Given this list of marker genes TMCO1, FOXN2, S100A11, MGST2, MTPN, PHYH, MICOS10, CHI3L1 (NCBI Gene Id 7836), MTM1, ECPAS (NCBI Gene Id 23392), CD68 (NCBI Gene Id 968), PDK3, FN1 (NCBI Gene Id 2335), RBBP9, IL15, STRAP, RAP1A, PDCD4, CASP1, TUBB6, OAT, ACTR2, NPAS1, C1orf43, LGALS4, PRDX2, SOCS2, CRIP1 (cysteine rich protein 1), FRRS1, ZNF808, TMEM167A, IFI30, TG, ITM2C, GLO1, SSPN, INPPL1, GNL2, UBE2E1, TUBB2A, ITM2B, TPD52, ARID3A, ADSS1, CHD1, RNF208, RAD54L, RNASE4, C15orf39, TAGLN2, TMEM131, RNASEH2B, MFHAS1, S100A6, RIDA, PPP2CB, GPHN, SCAMP1, SEPTIN2, S100A10, NID1, NEK2, SLC25A15, GGH, GIMAP4, NUDT19, FGL2, VMP1, LIPC, ASS1, INPP5A (NCBI Gene Id 3632), CDK5RAP3, SH3BGRL2, SBF2, FUT8, TMOD3, GBP7, TMBIM1, IGF1R, GCM2, DLAT, EMB, GBP4 (guanylate binding protein 4), PTPN22, HSD17B11, SLC25A4, S100A1, ACOT7 (NCBI Gene Id 11332), IDH2, UXS1, FSTL1, PSPC1, KNOP1, PSMD14, IRAK1, DDIT4, NAP1L1, SFXN1, IGKC, FAH, ITGA6, MCEE, CD9, TMEM230, KLHL9, ALDH7A1, SLC7A7, THUMPD1, ANXA7, REXO2, TMEM123, YIPF4, PRPS2, ANXA2, NEDD4, BACH1, GSTO1, CD80, TMEM176B, ZBTB20, VBP1, FAAH, CAPN2, KLHL7, PDE8A, ARIH1, LDAF1, UQCRB, XPOT, OTULINL, KCNA4, TRIM37, SPINK4, PEX7, EPCAM, NPM1, GJA10, SMPDL3A, KIF16B, SAR1B, CTSE, RSU1, SH3BGRL, STT3B, BAG1, IMMP1L, PIM1, FXYD5, PLAC8, SPTA1, HCK, LRRC58, ALG5, CFAP20, ALOX15, MGST1, CLCN7 (NCBI Gene Id 7814), RBBP7, S100A4, MPEG1, GCSH, UBL3, ATP11A, SUCLG2, TEP1, WDR77, SNRPB2, EPS8, TMED3, ADK, ADM, GLRX, ENO1, MFSD14A, PRDM1, RACGAP1, ALDH2, DNAJB9, CYP11A1, TOMM70, MCOLN2, MYC, LITAF, UCK2, SAA1, PEPD (peptidase D), CTLA4, CEP89, ATP5F1E, RER1, CBFA2T3, ZC3H12C, BMX, ABHD5, IL5RA, IL6ST, GPR137B, SLC66A3, UBE3A, TRIM11, here is a description of the gene set: from publication Walker LJ, Kang YH, Smith MO, Tharmalingham H, Ramamurthy N, Fleming VM, Sahgal N, Leslie A, Oo Y, Geremia A, Scriba TJ, Hanekom WA, Lauer GM, Lantz O, Adams DH, Powrie F, Barnes E, Klenerman P (PMID 22086415) Human Gene Set: GSE33425_CD161_HIGH_VS_NEG_CD8_TCELL_DN Genes down-regulated in CD8 T cells: KLRB1 high versus KLRB1-. This SuperSeries is composed of the SubSeries listed below. studied in species Homo sapiens